Given this list of marker genes Eif4e2, Gigyf2, Oas1e, Isg15, Inpp5d, Otop1, Nlrc3, A2m, Nlrx1, Dcst1, Smim30, Tyro3, Ifi214, Pparg, Lyar, Stat2, Serpinb9, Ins1 (insulin I), Banf1, Nlrp4f, Serpinb9e, Dusp10, Usp18, Nlrp4a, Ttll12, Grb2, Ifi203, Sfn, Nectin4, Susd4, Clec2d, Parp1, Arrb2 (NCBI Gene Id 216869), Parp14, Tap1, Ins2 (insulin II), Sh2d1b1, Ifi203-ps, Nmi, Atg5, H2-M3 (NCBI Gene Id 14991), Ythdf2, Cep63, Slamf8, Mill1, Ythdf3, Dhx58, Clec12b, Ifi207, Trim21, Rps19, Smpdl3b, Mmp12, Cactin, Serpinb9d, Aurkb, Acod1, Ptpn6, Mndal, Oas1c, Oas1d, Klrd1, Nlrp4b, H2-T23, Zdhhc18, Ifi208, Irak3, Oas1b, Serpinb9f, Drd2, Tnfaip3 (NCBI Gene Id 21929), Cnot7, Serpinb9c, Atg12, Cd96, Klrb1b, Serpinb9b (NCBI Gene Id 72011), Ifi213, Serpinb9h, Klre1, Mavs, Ccr1 (C-C motif chemokine receptor 1), Nectin2, Dnaja3, Ceacam1, Dtx4, Pim1, Gfer, Ywhaz (tyrosine 3-monooxygenase/tryptophan 5-monooxygenase activation protein, zeta polypeptide), Ddx39a, Grn, Oas1f, Tap2, Trafd1, Vsig4, Mettl3, Arg1, Samhd1, Serpinb9g, Oas1h, Usp38, Oas1a (2'-5' oligoadenylate synthetase 1A), Nlrc5, Fam3a, Nlrp4c (NCBI Gene Id 83564), Ptpn2 (NCBI Gene Id 19255), Havcr2, Adar (NCBI Gene Id 99861), Igf2, Serping1, Ifi206, Sh2d1b2, Oas3, Crk, Oas1g, Lgals9, Usp15, Ifi209, Trex1, Mul1, Tgfb1, Nlrp4e, here is a description of the gene set: species: Mus musculus Mouse Gene Set: GOBP_NEGATIVE_REGULATION_OF_INNATE_IMMUNE_RESPONSE Any process that stops, prevents, or reduces the frequency, rate or extent of the innate immune response.